Given this list of marker genes Maml1, Notch1, Nkx2-5, Bmpr1a, Kcnj8, Tbx5, here is a description of the gene set: The process whose specific outcome is the progression of the atrioventricular (AV) node over time, from its formation to the mature structure. The AV node is part of the cardiac conduction system that controls the timing of ventricle contraction by receiving electrical signals from the sinoatrial (SA) node and relaying them to the His-Purkinje system. studied in species Mus musculus Mouse Gene Set: GOBP_ATRIOVENTRICULAR_NODE_DEVELOPMENT